Given this list of marker genes LRRC8B, SLC13A3, SLC1A2, GRM1, GIPC1, PSEN1, ARL6IP1, TTYH1, FOLR2, AVP, SLC26A6, SLC25A13, PRKG1, SLC1A4, BEST1, SLC25A10, SLC16A1, SLC25A11, ABCC2, SLC17A6 (solute carrier family 17 member 6), GFAP, SLC1A5, ITGB1, SLC26A3, VPS54, UCP2, STXBP1, SLC13A5 (solute carrier family 13 member 5), LRRC8E, KCNJ10, SLC17A8, SLC26A2, P2RX7, SLC7A11 (solute carrier family 7 member 11), LRRC8A, SLC13A2, SLC26A10P, SLC1A3, AGXT, TTYH2, SLC26A4, NTSR1, FOLR3, GRM7, ADORA2A, SLC26A11, AVPR1A, PER2 (period circadian regulator 2), PRAF2, SLC1A6, SYT4, PIANP, SLC1A7, SLC22A6, SLC38A6, SLC26A7, SLC12A2, RAB3GAP1, DTNBP1, SLC25A21, LRRC8C, LRP2, SLC7A13, NF1, SLC26A5, SLC26A1, TRH, GJA1, ABCC8, SLC22A7, APBA1, FOLR1, ARL6IP5, GABBR1, ATP1A2, KCNK2, ABAT, SLC25A12, SNCA, SLC3A1, SLC38A2, SLC1A1, SLC19A2, KCNJ8, SLC17A7, SLC25A22, CLN8, ADORA1, KMO, PDPN, SLC25A32, GRM2, SLC19A1, TNF, EPM2A, SLC25A18, SLC46A1, SEPTIN2, SLC26A9, NTRK2, SLC26A8, TTYH3, NPY5R, GNAT2, LRRC8D, ABCC5, KCNK1, here is a description of the gene set: species: Homo sapiens Human Gene Set: GOBP_DICARBOXYLIC_ACID_TRANSPORT The directed movement of dicarboxylic acids into, out of or within a cell, or between cells, by means of some agent such as a transporter or pore.